The following is a description of a gene set: species: Mus musculus Top down-regulated genes from principal component 1 (PCA1) which captures variation between normal plasma cells and tumors arising from aberrant expression of BCL2L1 and MYC. Mouse Gene Set: BOYLAN_MULTIPLE_MYELOMA_PCA1_DN from publication Boylan KL, Gosse MA, Staggs SE, Janz S, Grindle S, Kansas GS, Van Ness BG (PMID 17483317) Multiple myeloma is an incurable plasma cell malignancy for which existing animal models are limited. We have previously shown that the targeted expression of the transgenes c-Myc and Bcl-X(L) in murine plasma cells produces malignancy that displays features of human myeloma, such as localization of tumor cells to the bone marrow and lytic bone lesions. We have isolated and characterized in vitro cultures and adoptive transfers of tumors from Bcl-xl/Myc transgenic mice. Tumors have a plasmablastic morphology and variable expression of CD138, CD45, CD38, and CD19. Spectral karyotyping analysis of metaphase chromosomes from primary tumor cell cultures shows that the Bcl-xl/Myc tumors contain a variety of chromosomal abnormalities, including trisomies, translocations, and deletions. The most frequently aberrant chromosomes are 12 and 16. Three sites for recurring translocations were also identified on chromosomes 4D, 12F, and 16C. Gene expression profiling was used to identify differences in gene expression between tumor cells and normal plasma cells (NPC) and to cluster the tumors into two groups (tumor groups C and D), with distinct gene expression profiles. Four hundred and ninety-five genes were significantly different between both tumor groups and NPCs, whereas genes were uniquely different from NPCs in tumor group C and genes were uniquely different from NPCs in tumor group D. Similar to human myeloma, the cyclin D genes are differentially dysregulated in the mouse tumor groups. These data suggest the Bcl-xl/Myc tumors are similar to a subset of plasmablastic human myelomas and provide insight into the specific genes and pathways underlying the human disease., and this is the list of marker genes: Cpm, Blvrb, Lhx2, Fstl1, Cnn3, Plk2, Egfl6, 2900026A02Rik, AI506816, Bcl2l1